Given this list of marker genes CBX2, MTA2, CBX8, CHD4, LAMTOR5, ATF2, RHEB, LAMTOR2, PTEN, RBBP4, RRAGC, TP53, MAF1, SCMH1, EGR1, GATAD2B (NCBI Gene Id 57459), SLC38A9, BMI1, RCOR1, CHD3, MTOR, RRAGD, SALL4, RRAGA, LAMTOR1 (late endosomal/lysosomal adaptor, MAPK and MTOR activator 1), PHC3, CBX4, GATAD2A, RRAGB, MLST8, MAPK1, CBX6, LAMTOR3, ATN1, HDAC2, RPTOR, MECOM, EZH2, EED, HDAC3, MTA1, SUZ12, LAMTOR4, MTA3, RNF2, HDAC5, JUN, RING1, RBBP7, PHC2, SNAI1, HDAC7, PHC1, SNAI2, NR2E1, MBD3, PPARG (NCBI Gene Id 5468), MAPK3 (NCBI Gene Id 5595), REST, HDAC1, KDM1A, here is a description of the gene set: Reactome Pathway: Regulation of PTEN gene transcription species: Homo sapiens part of: PTEN Regulation Transcription of the PTEN gene is regulated at multiple levels. Epigenetic repression involves the recruitment of Mi-2/NuRD upon SALL4 binding to the PTEN promoter or EVI1-mediated recruitment of the polycomb repressor complex (PRC) to the PTEN promoter. Transcriptional regulation is also elicited by negative regulators, including NR2E1:ATN1 (atrophin-1) complex, JUN (c-Jun), SNAIL and SLUG and positive regulators such as TP53 (p53), MAF1, ATF2, EGR1 or PPARG.